The following is a description of a gene set: species: Mus musculus Mouse Gene Set: MIR_669F_3P from publication Chen Y, Wang X (PMID 31504780) Genes predicted to be targets of miRBase v22 microRNA mmu_miR_669f_3p in miRDB v6.0 with MirTarget v4 prediction scores > 80 (high confidence targets)., and this is the list of marker genes: Mtmr6 (myotubularin related protein 6), Gabra2, Kcna2, Lmo3, Akap9, Sncaip (synuclein, alpha interacting protein (synphilin)), Bche, Dlx4, Ogfrl1, Klf2, Btf3l4 (NCBI Gene Id 70533), Prickle1, Fhip2a, 5730455P16Rik, Ssbp2, Slc23a2 (NCBI Gene Id 99086), Igf2r, Prkar1a, Slc4a7, Gabrb2, Arih1, Sfrp2, Tshz3, Zfp831, Gpr183, Pgr, Tec, Susd6, Cacna1c, Naaladl2, Xrn2 (5'-3' exoribonuclease 2), Mycn, Atad1, Chic1, Gpkow, Bmpr1b, Zfx (NCBI Gene Id 22766), Rnf38, Mcl1, Man1a2, Ptch2, Adcyap1, Lrrc42, Ralyl, Mosmo, Cdc42ep3, Tmem33, Mycbp2, Ttll7, Fbxo30, Pik3r1, Myf6, Fzd8, Capn1, Pappa, Dennd2b, Hook3, Xiap, Ppp1r15b, Rgmb, Klf12, Evi2b, Dek, Bri3bp, Il1rap, Pafah1b2, Myct1, Usp6nl, Slc30a10, Zc3h12c, Antxr1 (anthrax toxin receptor 1), Fbxl17, Myf5, Hmgxb4, Baz2b, Brd3, Gsk3b, Trib1, Otud4, Gstt3 (glutathione S-transferase, theta 3), Rbbp9, Adamts20, Msantd2, Syvn1, Gm5592, Carf, Spindoc, Etaa1 (NCBI Gene Id 68145), Zfp715, Dsc1, Amotl2, Nopchap1, Akap6, Dpm1, Zfp606, Ednra, Prkacb, Rabggtb, 1110059E24Rik, Loxl3, Map3k8, Rab6b, Kbtbd2, Ugcg, Taf4b, Sms, Hnrnpdl, 9330159F19Rik, Foxj3, Calhm5, Stxbp5l, Ints6, Suv39h1, Utp18, Ppp1r14c, Tmed7, Gopc, Csmd1, Stard13, Hecw2, Cnnm4 (cyclin M4), Tnrc6b, Kdm6a, Adamts17, Btaf1, Cxcl5, Pcf11, Ubap2l, Cysltr1, Crebrf, Med6, Ccdc166, Iqca1, Mfsd2a, Naa15, Zc3h7b, Nkx2-1, Dclk2, Zbtb10, Galr1, Lats1, Nedd9 (NCBI Gene Id 319669), Erich1, Lin54, Slc39a10, Slmap, Cxcl16, Cep192, Wipf3, Mbd5 (methyl-CpG binding domain protein 5), Irf2bp1, Vegfa, Sp100, Manea, Met, Ptp4a1, Lemd3, Lipg, Hivep1, Tbc1d4, Map4, Ank3, Myorg, Chmp4c, Pum2 (pumilio RNA-binding family member 2), Rsrp1, Adam22, Slc34a2, Mphosph9, Ino80d, Zbtb44, Tmem196, Tspan2, Glcci1, Evx2, Mef2a, Stard8, Pmp22 (NCBI Gene Id 18858), Grm3, Hsf2, Fgf4, Ttc7, Rbm39, Nup35, Fam43a, Arhgef7, Casz1, Wnt5a, Ncoa2, Rif1, Plxna2 (plexin A2), Vcf2, Nusap1, Hes1, Abca8a, Nedd4l, Rcan2, Ppat, Hopx, Aqr, Efr3b, Hivep2, Tcf12, Btbd7, Hnf4g, Arl6ip6, F3, Dnajc6, Jrkl, Pgm2l1, Taok1, Dpp6, Kif11, Sestd1 (SEC14 and spectrin domains 1), Zic1, Jag1, Herc2, Cry1 (NCBI Gene Id 12952), Scn2a, Extl3, Nsd1, Ppm1k, Aebp2, Psma3, Slc7a1, Tspoap1, Ctr9, Gucy1a2, Fat3, Dnm3, Sez6l, Zfp354c, Plekhg5 (pleckstrin homology domain containing, family G (with RhoGef domain) member 5), Bmp5, Nr3c1 (NCBI Gene Id 14815), Syt1, Prpf4b, Pdap1, Slc7a11, Prdm16, Mtor, Nptn, Nr1h5, Pdik1l, Ccnc, Ash1l, Slc38a1, Arhgap12, Nectin4, Gpcpd1, Dach1, Col5a1, Dlc1, Spc25, Hnrnpr, Ppp2cb, Nbea, Ankrd1, Zbtb14, Grhl3, Fech, Trpc1, Cdc14a, Ccdc102a (coiled-coil domain containing 102A), Crim1, Spag9, Erbb4, Mbnl1, Ptpre, Cntrob, Pdzrn3, Slc38a2, Ctdspl2, Slc35a3, Strn3, Gabrb3, Zcchc24, Ctdsp1, Hbp1, Sos1, Grb2, Arhgap29, Marchf5, Ercc3, Glis1, Rnf4, Ptprr, Cnot2, Erlec1, Arhgap44, Irs1, Prkce, Plekhg1, Tiam1, Cic (NCBI Gene Id 71722), Zxdb, Vcan, Cggbp1, Plcb1, Cspp1, Hs6st2, Ptbp3 (NCBI Gene Id 99962), Ncald, Hat1, Cldn17, Fbxo45, Atl2, Slc20a2, Nlgn1 (neuroligin 1), Nexmif, Ikzf2, Ric3, Pitpnb, Lypd1, Sos2, Cyth3, Fbxo43, Tmprss11e, Slc1a2 (NCBI Gene Id 98863), Adamtsl3, Tcf7l2, Cobll1, Klf15, Mast4, Vcam1, Itfg1 (NCBI Gene Id 71927), Adam9, Slitrk6 (NCBI Gene Id 239250), Kics2, Mab21l1, Itm2c, Tmem178, Phf6, Emp2, Ddx60, Akap12, Fut9, Steep1, Plag1, Carmil1, Scai, Trim63, Wdr44, Zswim6, Or52n4, Arhgef10l, Eda, Esrrg, Ss18l1, Nodal, Mbtd1, Dock1, Col19a1, Mef2c, Slc8a1, Dmxl1, Npy, Acvr2b, Bnip2, Cdr2, Sox9, Brd1, Traf3ip1, Arl8a, Paip1, Hmcn1, Rab2a, Pkd1, Sv2b, Zfp280d, Epha5, Syngr3, Mzt1, Vmp1, Ndel1, Dapk1, Cntfr, Apobec3, Irx5, Asap1, Stx7, Zfp248, Rasef, Slc28a3, Bbx, Nup133, Leprotl1, Fa2h, Edem3, Opa1, Jph1, Jcad, Sstr1, Atad5, Pitx2, Gtpbp2, Zfp518b, Usp12, Magoh, Dock3, Fam174a (NCBI Gene Id 67698), Hhip, Pdgfra, Tbx18, Casd1, Zfp236, Cbfb, Zbtb49, Spryd7, Acr, Gdap2, Tbc1d15, Pcdh11x, Arid4b, Dnajb12, Sstr2 (NCBI Gene Id 20606), Usp42, Pafah1b1, Pcsk2, Ppp1r7, Tspan12, Fnbp4, Ano1, Stat3, Vwc2l, Irx1, Trh, Optn, Phactr4, Adamts1, Cldn23, Klf4, Id1, Ism1, Crebzf, Bnc1, Gtf2b, Thrb, Kcnh5, Zc3h4, Myo5b, Slc5a1, Ripply2, Crx (cone-rod homeobox), Zcchc8, Cab39, Cdk19, Cpne3, Ing1, Sik1, Morf4l2, Igfbp1, Cecr2, Fnip1, Adgrl2, Necap1 (NECAP endocytosis associated 1), Kmt2c, Rpain, Mrpl39, Twist2, Dnm2, Camk2d, Eml6, Eid2, Nphp3, Wnt3, Ndnf, Rbm27, Zfp608, Tafa1, Mamdc2, Simc1, Meox2, Rab3gap2, Asic4, Oga, Stk24, Il18rap, Paxbp1, Slc6a8, Trhr, Fgf12, Plac9, Whamm, Arpp21, Irx3, Zfyve21, Usp7, Lin28a (lin-28 homolog A), Aftph, Bcl2l11, Robo2, Tanc2, Cyp26b1, D630023F18Rik, Zfp93, Mitf, Cbx5, Far1, Wee1, Rfx8, Thbs2, Rab11fip2, Slc30a4, Stk17b, Snrk, Arhgap6, St8sia4, Vps26a, Ccnb1, Trp53inp1, Crybg3, Exosc7, Ppp1r21, Nsmce4a, Kif20b, Arid1a, Grk5, Asf1a, Ccar2, Terb2, Inpp5b, Hexim1, Bdnf, Sox21, Cxadr, Zmym2, Mtf2, Cadm1, Rbm25, Rasal2, Twist1, Usp29, Ets2, Dll4, Zfp131, Camsap2, Tmem236, Dagla, Golt1a, Vezf1, Rab18, Rabgap1, Foxq1, Cav2, Serpini1, Atp2b4, Ccna2, Kdm3a, Ppp1r26, Hectd1, Efcab14, Yy1, Arid5b, Marchf6, Prkaa1, Gnb4, Dll1, Sema3d, Ifngr1, Usp31, Zfp148, Timm10, Adgrb3, Rgs4, Zic3 (NCBI Gene Id 22773), Foxj2, Ppm1h, Spry1, Pum1, Abi1, Nktr, Denr (density-regulated protein), Gas1, Ccdc126, Nceh1, Pclo (NCBI Gene Id 26875), 1110059G10Rik, Vps13d, Alg1, Camta1, Tet2, Daam1, Col11a1, Mob4, Anks1b, Tmem161b, Foxa1, AI182371, Nog, Ing3, Zmym3, Msi2, Sun1, Tet1, Eps8, Camk1d, Ptpra, AW554918, Sorcs3, Zc3h11a, Zc2hc1a, Btnl9, Phf12, Adamts5, Nek1, Tmc8, Spred1 (NCBI Gene Id 99293), Bcl11b, Snx12, Znrf3, Foxc1, Ccr2, Arl14epl, Gm15881, Unk, Lzts2, Rab8b, Tmprss11b, Stam2, Dcun1d4, Ythdc2, Golga2 (golgin A2), Mysm1, Mrtfa, Rab3c, Snx14, Lmo1, Nom1, Brcc3, Lcorl, Rai1, Rb1cc1, Pten, Cd200r1, Ccdc185, Chd1, Itch, Tm4sf4, Dbx1 (NCBI Gene Id 13172), Slc25a16, Efna5 (NCBI Gene Id 13640), Lamtor5, Lef1, Lgr4, Htr5a, Ice1, Avl9, Dcun1d3, Spink5, Pter, Foxd4, Rbm5, Hoxa9, Fam171a1, Zbtb7a, Adck1, Fam199x, Rbl1, Zbtb22, Kit, Nfat5, Foxo1, Tfb1m, 1810062G17Rik, Slc30a5, Fam76b, Smoc1, Srgap3, Adarb1 (adenosine deaminase, RNA-specific, B1), Rasgef1a, Oprk1, Adgrg2 (adhesion G protein-coupled receptor G2), Tmem68, Ube2w, Car10, Arap2, Zfp518a, Nfyb, Topbp1, Ensa, Inpp4a, Malt1, Spry2, Xrcc2, Ncf1, Pcdh8, Mbnl3, Homer1, Tab3, Tbr1, Rab11fip1, Tm9sf3, Fgd4, Ap1b1, Lmbr1, Tgfbr1, Zfp182, Cdkn1b, Dmtf1, Pik3c2a, Pias1, Dleu7 (NCBI Gene Id 239133), Pou4f2, Pik3ca, Cds2, Abca14, Raph1, Itga2, Uty, Pip5k1b, Stx12, Ccn3, Cttnbp2, Creld2, Srek1ip1, Ppp2r5e, Rassf5, Smad9, Acp2, Bmper, Insm2, Cadm2, Tek, Rock2, Prkg2 (protein kinase, cGMP-dependent, type II), Nufip2, Ifrd1, Wsb1, Cilk1, Diaph2, Cks2, Vstm4, Orc1, Vps33b, Sh3rf1, Prkcd, Zfp292, Impact, Cflar, Clspn, Nkx2-9 (NCBI Gene Id 18094), Epc2, Rnf24, Fbxo33, Nfkbia, Fgfr2, Trappc6b, Itga4, Rras, Kif3a, Nr5a2, Cacnb2, Cbln4, Mbd2, Nemf, Grm5, Ttc8, Tubgcp5, Psd3, Sbf2, Kif23, Tut4, Ahdc1, Hoxd1, Epc1, Pou3f2, Cnot6l, Iars2, Prdm1, Scamp2, Rasgrf1, Bltp1, Syncrip, Penk, Col25a1, Psmd5, Clip1, Slc6a19, Plch1, Fndc3b